Given this list of marker genes SYT10, PRKCG, FBXL20, SYK, RABGEF1, TRPV6, SV2C, SYT12, F2RL1, CCR2, IL4R, FERRY3, CACNB4, CASK, CSPG5, LAMP1, PRKCB, CD160, RIMS2, AP1G1, SYT5, RIMS3, SYN1, FOXF1, VAMP8, ZP3, RPH3A, GAB2, PRAM1, CD177, PDPK1, SYT13 (synaptotagmin 13), FMR1, SNX4, RAB3A, SPHK2, RAB3GAP1, P2RY1 (purinergic receptor P2Y1), RAB15, RPH3AL, NLGN1, GPR151, SPI1, DVL1, SYT6, UNC13D, STXBP3 (syntaxin binding protein 3), SYT7, SEPTIN5, GATA1, SYT9, DTNBP1, DOC2B, STXBP1, ADRA2A, SYT4, MICAL1, STX1A, FGR, GATA2, ADORA2B, HYAL3, RAC2, ITGB2, LYN (LYN proto-oncogene, Src family tyrosine kinase), WNT7A, DOC2A (double C2 domain alpha), RAB5A, RAP1A, SYT17, SYT15, STXBP5, RAB27A, HLA-F, PREPL, SV2B, CD84, IL13RA2, SYT2, FCGR2B, CACNA1B, NOTCH1, SCAMP5, PPFIA2, P2RX1, SYT8, GIT1, KCNB1, SYT1, BAIAP3, CDK5R2, VPS18, LGALS9, RAP1BL, SYT11, LRRK2, VAMP7, BRAF, CEACAM1, PPP3CA, RAB3D, CD300A, FCER1G, RAP1B, KLRC2, RIMS4, ADGRE2, NPY, CALM3, GNAI2, STXBP2, ITGAM, FES, PLA2G3, SNAPIN, SLC4A8, RIMS1 (NCBI Gene Id 22999), CBARP, SYT3, IL13 (interleukin 13), STX4 (syntaxin 4), CDK5 (cyclin dependent kinase 5), FBXO45, ATP2A2, REST, PFN2, BCR, NCKAP1L, here is a description of the gene set: Human Gene Set: GOBP_REGULATION_OF_REGULATED_SECRETORY_PATHWAY studied in species Homo sapiens Any process that modulates the frequency, rate or extent of regulated secretory pathway.